Given this list of marker genes ANAPC7, ANAPC15, CDC23, BUB1B, CDC26, ANAPC4, UBE2D1, UBE2S, CDC27, ANAPC10, ANAPC2, UBE2E1 (ubiquitin conjugating enzyme E2 E1), ANAPC1, CDC20, CDC16, BUB3, ANAPC11, ANAPC5, ANAPC16, UBE2C, MAD2L1, here is a description of the gene set: Human Gene Set: REACTOME_INHIBITION_OF_THE_PROTEOLYTIC_ACTIVITY_OF_APC_C_REQUIRED_FOR_THE_ONSET_OF_ANAPHASE_BY_MITOTIC_SPINDLE_CHECKPOINT_COMPONENTS Inhibition of the proteolytic activity of APC/C required for the onset of anaphase by mitotic spindle checkpoint components studied in species Homo sapiens